Given this list of marker genes MED22, CDK4, TAF4B (TATA-box binding protein associated factor 4b), GTF2A2, PAXIP1, PWWP2A, MED21, TAF3, HEY2, HNF1A, HMGB1 (high mobility group box 1), FOXO1, PSMC6, MED18, CREB1, MED17, TAF9, TAF1, TP53, MED25, MED20, MED12, MED30, GTF2A1, JUN, MED26, MED9, ZNF451, MED24, MED7, WNT10B, THRA, CEBPA, MED14, TAF7, XPA, MED29, TAF2, ERCC6, MORC1, MED27, NFKBIA, TAF5, CTNNBIP1, NFKB1, NKX2-5, MYC, MED6, TAF6, SETX, MED10, MED8, MED16, PPM1D, MED1, MED31, TAF8, TWIST1, HNF1B, SRF, MED11, TAF11, MED13, MED28, KAT8, ZNHIT1, MED15, TAF4, BCLAF1, TAF10, MED23, MITF, MED4, MED19, RRN3, DHX36, ERCC1, TAF12, TAF13, FOSL1 (FOS like 1, AP-1 transcription factor subunit), SUB1, TBP, CAND1, here is a description of the gene set: Human Gene Set: GOBP_REGULATION_OF_DNA_TEMPLATED_TRANSCRIPTION_INITIATION species: Homo sapiens Any process that modulates the frequency, rate or extent of DNA-templated transcription initiation.